The following is a description of a gene set: Sphingolipid de novo biosynthesis Human Gene Set: REACTOME_SPHINGOLIPID_DE_NOVO_BIOSYNTHESIS species: Homo sapiens, and this is the list of marker genes: VAPB, SPTLC3, VAPA, CERS6, SPTSSA, MFSD2B, ORMDL2, CERT1, PRKD2, FA2H, DEGS2, CERS4, DEGS1, SPTLC1, OSBP, PRKD1, ORMDL3, CERS5, CYB5B, SGMS1, KDSR, SAMD8, SPTLC2, ABCG2, CERS2, SPHK2, CERS3, ORMDL1 (ORMDL sphingolipid biosynthesis regulator 1), CERS1, SPTSSB, ABCC1, PPM1L, PRKD3, SPNS2, SPHK1, SGMS2, CSNK1G2